Given this list of marker genes HLA-DRB1, DNA2 (NCBI Gene Id 1763), CYP27A1, MEIS2, NRCAM, VPS33B, UBAP2L, PIGB, KDSR, MAB21L2, GTPBP2, TBX22, FBXO11, BRCA1, USF3, POLR3GL, LUZP1, MPV17, OPA3, RNF2, TMEM216, STX5, YY1, XYLT1, CD96 (NCBI Gene Id 337949), CREBBP, USP9X, GATA6, SIN3A, TUFT1, BMP2, DGCR2, SOD1, SLC25A4, PRG4, SF3B4, DMD, TMEM260 (NCBI Gene Id 54916), SMO, RALA, BAG3, HNRNPH1, RAI1, KBTBD13, WASHC5, CCDC22, FLI1, AGA, ASXL1, CERT1, ERCC6, CUL4B, VCP, ZNF668, KIF7, SLC5A7, BUD23, CPT1C, PCGF2, WNK3, MYOD1, NFU1, SLC26A2, PARN, GRIN2B, LAMA3, HK1 (NCBI Gene Id 59333), BMPER, NPHP1, RAD51C, POLRMT, AHDC1, SUFU, IBA57, KIF1A, PCNA, TDP1, TTC21B, AMMECR1, PALB2, TRIO, MBTPS2, PDGFRB, COA7, LITAF, MYRF, BMPR1B, IFIH1, VPS13A, DLG4, ACBD6, GJB4, ADAMTS15, TPR, ATP1A3, MEF2C, SLC18A2, DNM2, RAB7A, SPEG, CASK, TRIM8, NLRP3, MYOT, KCNA1, TACR3, LZTR1, BRIP1, ABL1, HSPD1, BBS12, FGF14, TOGARAM1, DYNC2I1, ANAPC1, ITCH, RBM8A, RAD21, HEATR3, RINT1, TSPOAP1, B3GLCT, PTEN, ATG7, KRT74, HOXA13, POLR1A, CNTNAP2, ATP6V1E1, LMX1B, FLVCR2, ADA, PSAT1, GAN, MED25, IGF1R, GRHL2, SACS, PTH1R, ARMC9, ALOXE3, COL3A1, FGF8, TNNT1, ORAI1, BPNT2, MME, LTBP4, SCN4A, SLC9A6, ATPAF2, NPM1, KATNB1, BLTP1, DSG1, PRMT7, FGF9 (fibroblast growth factor 9), SPAST, SLCO2A1, BRD4, PQBP1, MCOLN1, SERPINA12, TCF20 (NCBI Gene Id 6942), FOXE3, CCN6, EXOC6B, YME1L1, DHTKD1, CSGALNACT1, MKKS, FLNA, SLC9A7, SPTLC1, RUSC2, GNPTAB, ALG2, NDRG1, GRIA3, RYR1, TUBB3, COL1A2, TRMT10A, IDS, ARL13B (ADP ribosylation factor like GTPase 13B), CRKL, SLC35A3, MATN3, CASZ1, CBY1, H1-4, IARS2, INPPL1, HCN1, REPS1, COL17A1 (collagen type XVII alpha 1 chain), KPNA3 (NCBI Gene Id 3839), KRAS, KLC2, SIL1, CTBP1, ALAD, BBS2, SETD2, PLAA, APC, DHCR24, SEC23A, PLA2G6, NAA20, GRIN2A, CACNA1C, MTRFR, CAVIN1, HEY2, KRT1, DACT1, RYR3, ALPL, HBA2, GLI1, PIGP, GNB4, GBE1, PEX2 (peroxisomal biogenesis factor 2), KDM5A, ASXL3, DCC, TAFAZZIN, SCN2A, CEP104, ARHGAP31, SGCG (sarcoglycan gamma), TFE3, POMGNT1, SMARCAD1, SYNE2, GORAB, NOTCH1, IQCE, FUZ, PDZD8, SPRTN, SVIL, LAMC2, DHX30, TAF6, MYO9A, NDE1, PRKACA, MAP1B, VLDLR, SLC17A5, CLCN3, NBN, DYM (dymeclin), MAP3K20, SLC33A1, ABHD12, CLCF1, SLC2A10, SIM1, FBXO38, BBS4, SNCA, IFT74, HSPB1, NOD2, PLEKHG5, GJA1, GLB1, REEP1, CDSN, WARS1, CTU2, DRG1, MUSK, TMEM138, TMEM107, MEG3, SLC39A13, STX1B, TNFRSF1B, KANSL1, MKRN3, CRIPT (CXXC repeat containing interactor of PDZ3 domain), CLTCL1, DLAT, POMT1, UBE3B, UBAP1, PIGL, TTPA, POR, NCF1, GJB2, FKTN, MMP14, USP7, ADAT3, AKT1 (NCBI Gene Id 207, AKT serine/threonine kinase 1), RMRP (RNA component of mitochondrial RNA processing endoribonuclease), NRAS, HGD, RFX7, RAB23, BCR, DLL4, WDR11, HACE1, ARL6IP1, BMP4, KDELR2, ERCC1, CAPN3, MYH14, RECQL4, GMNN, KATNIP (NCBI Gene Id 23247), FAM20C, CUL7, DNM1L, KIAA0586, CYP4F22, COL6A3, GTF2IRD2, FBN1, FGFRL1, PPIB, MED12L, KIF5C, NADSYN1, TMEM231, DMPK, PPP2R3C, SPG7, SATB2, BRPF1, ADGRG6, SYT1 (synaptotagmin 1), TGFB2, FBXW11 (F-box and WD repeat domain containing 11), TGFBR2, NECTIN4, ANO5, ANO10, SOX18, TOR1AIP1, LIMS2, PUF60, SMARCA2, PTCH2, TXNDC15, ZEB2, TELO2, MED13L, IFT43, GBF1, MEN1, TLK2, COL6A2, ASAH1, DNAJB2, ECEL1, GJA5, B3GALT6, RAD51, TRAPPC11, IFT52 (intraflagellar transport 52), MAFB, NPR2, CST6 (NCBI Gene Id 1474), UBA1, GMPPB, FREM2, PRKACB (protein kinase cAMP-activated catalytic subunit beta), TTI1, MYT1L, PLIN4, ACVR1, CC2D2A, NHP2, NPR3, ATCAY, MYL2, USB1, FANCG, ANK1 (NCBI Gene Id 286), BMS1, FDX2 (ferredoxin 2), FREM1, TBC1D23, COL2A1, TERT, PDE6D, MBD5, PRUNE1, ANO1, BBIP1, RBPJ, STAG1, FLRT3, CSNK2A1, MAP2K2, LMBR1, CBFB, EIF2AK2, RSPRY1, ORC6, DDHD2, DLK1, ZNF148, GTF2E2, FGF13, TLL1, KDM4B, INPP5E, LORICRIN, JUP, ANOS1, SNAP29, TAOK1, SUMF1, PDPN, SLC12A6, ZSWIM6, WIPI2 (WD repeat domain, phosphoinositide interacting 2), HERC2, RNF6, XRCC4, TCTN3, TBX15, EPS15L1, SORD, SALL1, C2CD3, CD4, CEP19 (NCBI Gene Id 84984), RHOA, ADGRV1, TAT, RAB11B, TPM2, GSC, FAM50A, PLOD3, SAMD9, U2AF2, WRN, HSD17B4, SOX10, MEGF8, VAC14, LARS1, ESAM, PIEZO2, CYP7B1, TBC1D24, PRKCG (protein kinase C gamma), TTC8, SCLT1, TRRAP, IFT122, RTTN, FGF17 (fibroblast growth factor 17), DNMT3A, EIF3F, SEC24C, PIGF, XRCC2, ADAMTSL2, AQP5, KIDINS220, HPGD, FGD4, TRAIP, MTOR, VPS13D, CAMTA1, MYPN, PTHLH, NUP188, SMAD4, USP8, KRT10, DOK7, KRT17, HDAC6, STS, IFT80, SCN9A, BIN1, NONO, MFN2, CEP290, MARS1, EHMT1, GMPPA, PACS1, COL1A1, MYMK, DHODH, UFC1, FKBP10, KIAA0319L, MAN2B1, FMR1, AP4B1 (NCBI Gene Id 10717), MAT2A, DCLRE1C, KLK11, IFT56, NEUROD2, DSC2, CACNA1A, LRP5, MFAP5, NT5C2, GDF5, NKX2-6, ZDHHC9, EBP, FDFT1 (NCBI Gene Id 2222), KANK2, H4C3, EXOSC3, DPH1, PAPPA2 (NCBI Gene Id 60676), MED12, CNTNAP1, SMARCAL1, PI4K2A, AEBP1, ZFYVE26, MAF, DYNC2I2, TBCK, DPH5, PRKAR1A, SMPD4, FGF10, KIF5A, MMP2, ABHD16A (NCBI Gene Id 7920), KCNK9, IGHMBP2 (immunoglobulin mu DNA binding protein 2), MAX, IDUA, HEPHL1, KLHL41, FXN, TRIM2, FHL1, COX7B, PDE4D, GJA8, SLC10A7, MAP2K1, EIF5A, KMT5B, KCTD1, SCN1B, SMG9, GFPT1, SLC25A22 (solute carrier family 25 member 22), MSTO1, TYMS, PHF6, SVBP, PYCR1, COL5A2, TRMT1 (tRNA methyltransferase 1), HIRA, EFEMP1, GABRD, NPAP1, MFSD2A, PDHA1, TH, JAG2, AFF3, MYH8, NUP88, LAS1L, DOCK6, CPT2, ACTB, SMARCA4, TRIP11, PTPN22, CHD6, BRWD3, RPGRIP1, MRE11, KCNJ5, RPL10, TRPV4, PEX7, TXNL4A, OTUD6B, MET, TBX5, RBBP8, STAC3, TTI2, PITX1, PYROXD1, AHCY, COQ8A, KRT83, ARL6, DHX16 (DEAH-box helicase 16), INSR, GNPTG, FBXL4, WAC, PTRH2, COL7A1, B4GALT7, FGFR3, ZBTB20, SEMA3A, SLC25A1 (NCBI Gene Id 6576), UPF3B, HNRNPK, NF1, METTL23, EIF4A3, ATAD1, ERBB2, KMT2D, FGF16, RLIM, SOX4, LETM1, EMG1, SYNJ1, WASF1, EIF2S3, PRRT2, IRF5 (NCBI Gene Id 84729), BBS9, NXN, ERLIN2, SMS, ELN, REV3L, THOC6, MTMR14, CCNQ, CEP120, NEK9, CDC45, ARID1A, TGDS, C19orf12, PHF8, LIG4, CEP152, BHLHA9, LTBP3, PI4KA, EOGT, PMM2, SOX9 (NCBI Gene Id 6662), HOXD13, WNT10B, RNU4-2, B4GAT1, MTM1, SLC35D1, XYLT2, TFAP2B (NCBI Gene Id 7021), PEX6, CNOT2, PLK4, VIPAS39, KNSTRN, BMPR1A, NDN, TRMT5, ERCC5, ABCA12, HADHA, SYNE1, TBR1, FKRP, GPC4, KIF22, ACTA1, TAF4, FRAS1, WDR19, ARCN1, CDK10, RTL1, VRK1 (NCBI Gene Id 7443), COMT, PEX1, HAAO, TCF4, KRT85, NLRP1 (NCBI Gene Id 82286), VPS35L, ACTA2, KAT6B, KDM5C, HPRT1, SLC6A9, AAAS, SLC25A19, DDR2, POMGNT2, CAPN1, ORC1, CLCN4, MLXIPL, FBLN1, JPH1, ATR, UBE2A, ADCY6, ADSS1, RSPO2, TMEM237, CFL2, GALC, CTH, RELN (NCBI Gene Id 5649), FANCM, NDST1, MGP, GHR, NIPBL, SELENON, NEK8, MAN1B1, GAD1, TAF8, MSX1, LEMD3, ALMS1, HBA1, MYH7, YARS1, ATRX, AP4M1, RREB1, TBL2, BSCL2 (NCBI Gene Id 84753), BBS5, TMEM67, PEX5, SNX14, SNRPN, PNPLA6, FA2H, COMP, COL13A1, ATRIP, ADPRS, DSP, KIF1B (NCBI Gene Id 57598), DGCR6, PPP1R15B, MAPK1, ZNF423 (NCBI Gene Id 23090), AUTS2, TBX1 (NCBI Gene Id 7413), CIC, TCTN2 (NCBI Gene Id 79867), HADHB (NCBI Gene Id 3032), SERPINB7, PHYH, APTX, HEXB, GOSR2, KIAA0753, KRT5, NUP107, SMARCD2, TAF1, NDNF, SASH1, FIBP, CHST11, RXYLT1 (ribitol xylosyltransferase 1), GFM2, HUWE1, RFWD3, ALDH18A1, ATP2B1, PNPT1, GDF6, GNAS, H4C5, FBN2, EIF4H, CERS3, FLNB, DPYS, PTPN2, CAMK2G (calcium/calmodulin dependent protein kinase II gamma), KIAA0825, PEPD, ERF, BGN, NUP85, NSD2, VWA1, CDC42BPB (CDC42 binding protein kinase beta), HIVEP2, RIN2, TBC1D2B, CARS1, SIK1, POMK, SMC5, HTT, APC2, TRPM4, NKX3-2, SEM1, EGR2, WRAP53, SPART, FOS, NECTIN1 (nectin cell adhesion molecule 1), PDK3, SLC37A4, CCDC8, BBS10, RAB34, WNT7A, CTSC (NCBI Gene Id 50958), SCNM1 (NCBI Gene Id 79005), ALG8, RBM10, LAMA5, WLS, TRPM3, SDCCAG8, LRSAM1, FBXO7, PUM1, GCH1, HNRNPA1, COQ7, HARS1, STXBP1, FANCD2, NIPA1, ARSL, RET, DLG5, BAZ1B, IFT57, PLXND1, IQSEC2, COL11A2, SLC25A46, KCNH1, CBS, ASCC3, ERCC4, DYNLT2B, FANCL (FA complementation group L), FANCI, SBF2, CHRM3, PRR12, SCARF2, ASPH, NELFA, SOX5, DDHD1, KCNJ2, SUZ12, VARS1, CCR6, SMC1A, FAT4, TWIST2, CENPE, IL7R (NCBI Gene Id 3575), THSD4, UBE2T, GJC2, DDX11, IRF6, MTR, GNAI1, PIGG, NTNG1, ERGIC1, MIR17HG, ZNF141, RFT1, GBA2, MAGEL2, CADM3, DNAJC30, CD247, PEX10, HNRNPH2, AMER1, CCDC28B, PLOD1, SLC25A24, DUSP6, PSMB8, SHH, WWOX, DPM1, SHMT2, ARVCF, SGCA, RNU4ATAC, RPS6KA3, TRIP4, GNAO1, SPG11 (SPG11 vesicle trafficking associated, spatacsin), CFAP418, DONSON, DYNC2H1, NKX2-5, TONSL, ALDH6A1, HS2ST1, OTUD5, NEFL, ZIC3, SPEN, LGI4, PIGA, GJB1, NAA10, CSPP1, CPLANE1, VPS41, ATP1A2, FOXG1, FAM149B1, MTX2, DNAJC6, MSL3, ADK, TRIM32, ZMYM2, PLAAT3, PTCH1, NSDHL, SMAD3, AP1G1, CHMP1A, ASNS, H3-3A, ROR2, SLX4, MYMX, KCNN3, GABRA1, SRD5A3, TERC, PPM1D, CCNK, KYNU, COL12A1, PLEC, ALG12, COL6A1, CAV1, CIBAR1, ERI1, WNT5A, ATP2A2, RAB3GAP1, SON, CPLX1 (complexin 1), RIT1, TCTN1, SCYL2, ARID1B, TMEM94, TBX4, AP1B1, CRLF1, PMPCA, SLC4A10, CLIP2, TET3, PRX, ATP6AP2, TGM1, NEDD4L, TOR1A, HEPACAM, KLLN, B4GALNT1, NSD1, JMJD1C, GALNT2, TBX3, PPP2R1A, ANKRD55, HS6ST1, FERMT1, IL2RB, DMXL2 (Dmx like 2), ERCC8, HINT1, KRT6B, EXT2, SPTBN1, CHD8 (chromodomain helicase DNA binding protein 8), PPARG, PIK3CA, EIF2AK3, FKBP6, IL17RD, PCDHGC4, DSE, LRP4, SYT2, DGCR8, CTSK, SLC29A3, GNS, OBSL1, ERMARD, XPA, WDR35, TWNK, PRDM16, METTL27, SCN1A, RSPO1, BAP1, SNORD115-1, FANCE, ADAMTSL1, GPC3, TGFB3, DDX59, KAT6A, COG6, NSUN2, CAV3, COL4A1, CCDC47, SPTAN1, CHRNG, CAST, UBA2, TMTC3, ERCC2, LONP1, COL25A1, GRIN1, OPA1, BBS7, VPS37D, SPRY4, B3GAT3, AIFM1, PNPLA1, MECP2, WARS2, CHSY1, HNRNPA2B1, GNB1, ARL6IP6, LBR, UFD1, DPAGT1 (NCBI Gene Id 1799), ITPR3, POGZ, DLX5, CANT1, RETREG1, CHST3, NDUFAF6, PIBF1, PROK2, DCPS, CTSB, SMAD2, DYRK1A, B3GALNT2, DPM3, SMARCE1, SDR9C7, GRIP1, BICD2, ATP9A, TMEM270, MAN2C1, CILK1, DDX6, FARS2, AHI1, NFIX, SMC3, GATA4 (GATA binding protein 4), PDXK, TMCO1, HERC1, SEC23B, INTS8, SCAPER, EDEM3, TNNI2, FLII, SIGMAR1, PIK3CD, LMNA, FBXW4, NEFH, PRKCZ, B9D2, ATL3, DAG1, PCDH19, DLEC1, INTS1, IVNS1ABP, TDO2, IFRD1, ZMIZ1, SBF1, CCN2, GLI3, ARSI, PEX26, EXT1, MYCN, FLRT1, TRPV3, FANCA, ATP7A, LMBRD1, TRIP12, ATP13A2, COL27A1, TINF2, ZMPSTE24, MYH11, TMEM218, SETX, LMNB2, PIGS, MAPRE2, CHST14, ESS2, SCAF4, SRY, MRAS, WDR26, MTMR2, C1R, NKAP, NPHP3, SHROOM4, BTRC, MMP1, EVC2, AIP, ROBO1, LIFR, NOTCH2, GNA11, TBL1XR1, TMEM43, HDAC8, SULT2B1, MTTP, GDF11, ADAMTS10, DCHS1, MYL11, EFNB1, PRKD1, PHGDH, PMP22 (NCBI Gene Id 5376), LIPE, RPGRIP1L, BCOR, BBS1, CTCF, MCTP2, MAP3K7, DVL1, PPP3CA, BRCA2, PWAR1, KMT2A, CHD3, EN1 (engrailed homeobox 1), VPS13B, EED, FANCF, NARS1, IFT27, RERE, COPB1, MAD1L1, FGD1, EZH2, FANCC, SEC31A, ATP6V0A2, EEF1A2, GZF1, SCYL1, KMT2B, IRX5, IL6ST, NBAS, ZNF699, MGAT2, WNK1, IMPDH2, HACD1, POLR3A, CKAP2L (NCBI Gene Id 150468), CDH3, WBP4, POMT2, HNRNPR (NCBI Gene Id 10236), GABRA3, PRKG1, COL11A1, STX1A (NCBI Gene Id 6804), NEB, ATP6V1B2, WDR73, ZC4H2, SLC35C1, OFD1, UBE4B (ubiquitination factor E4B), PLP1, COG8, PIGQ (NCBI Gene Id 9091), KRT9, ATP6V1A, CHCHD10, PAICS, MMP23B, COG4, VAMP1, MEGF10, SNIP1, GJB6, PRDM5, CRPPA (CDP-L-ribitol pyrophosphorylase A), SLC32A1, SLC39A8, COASY, SDHC, REEP2, TAF2, NR4A2, CDC42, BCAS3, PMP2, COX4I1, GRIA2, CEP295, PODXL, ATL1, KCNJ8, ADAMTS2, AAGAB, SH3TC2, STAG2, SEMA3E, SLC31A1, FGFR1 (NCBI Gene Id 84151), PLOD2, SCO2, IFT172, FEZF1, WDPCP, RAG2, GRIN2D, IFT140, ADNP, VANGL1, HOXD10, TPM3, DYNC1H1, H4C11, NOP10, NIPAL4, SIK3 (SIK family kinase 3), PPP1R21 (protein phosphatase 1 regulatory subunit 21), SLC16A2, RHBDF2, L1CAM, CEP55, NEK1, PROKR2, HRAS, KY, EMILIN1, SLURP1, CSTA, FANCB, KRT2, PIGH, PYCR2, LIMK1, GABBR2, SKI, COL14A1, SLC1A3, AP4S1, GRM7 (NCBI Gene Id 2917), KRT6A, RIPK4, SNORD116-1, KCNAB2, SETD5, IPO8, EXTL3, IL2RG, KARS1, H3-3B, ATP5F1D, HSPG2, GNPNAT1, SAMD9L, COL9A1, MAD2L2, EPB41L1, LAMB2, NGLY1, CCT5, UCHL1 (ubiquitin C-terminal hydrolase L1), POLG, ZNF469, GATAD2B, MT-TE, FGFR2, TYROBP, C18orf32, ALOX12B, BRAF, ALG3, DKC1, KRT14, SC5D, CTDP1, ZFX, PNKP, DYNC2LI1, SH3PXD2B, CEP41, TRPS1, LARGE1, CNOT3 (NCBI Gene Id 9756), EMD, TFG, ITGB4, SALL4, SLC1A4, RAB33B, MORC2, TGFBR1, COL5A1, LAMB3, BRF1, RAB3GAP2, PHIP, RAP1GDS1, FIG4, PIGV, COL9A3, GUSB, RTEL1, GABRG2, POMP, PKP1, GPX4, SDHD (succinate dehydrogenase complex subunit D), FRA10AC1, RAG1, DHH, PWRN1, WDR81, CHAT, CRELD1, PPP1R13L, ENTPD1, GBA1, MAPK8IP3, INF2, GTF2IRD1, ENPP1, NOG, CCDC141, SLC35A2, HSPB8, IL2RA, TP63, SPECC1L, TTN, JAG1, SIAH1 (NCBI Gene Id 6477), MPZ, AGPAT2, SHANK3, SARS1, EBF3, KLHL24, PCNT, H4C9, LAMP2, CD28, SPIN4, RFC2, ARX, HYLS1, GARS1, GDAP1, CTLA4, MRPS28, UNC80, ALDH1A2, TOPORS, VAPB, ALG9, IHH, PIGN, WNT10A, ATN1, SHOX, MYLK (myosin light chain kinase), GLDN, COLQ, AP4E1, CDKL5, IFITM5, TGFB1, KLHL9 (kelch like family member 9), DHCR7, MYBPC1, FILIP1, GP1BB, POC1A, SLC6A8, PRKG2, TWIST1, STAT4 (NCBI Gene Id 6775), CTNNA2, CHP1, MYH3, SLC12A2, TNNT3, GTF2I, NALCN, PPP2R5D (protein phosphatase 2 regulatory subunit B'delta), CFTR, DCAF8, TBCE, KAT8, DEAF1, ALG14, GNE, GLE1 (NCBI Gene Id 8012), FKBP14, GJB3, PIGO, FITM2, BPTF (bromodomain PHD finger transcription factor), DES, CCBE1, LOX, CACNA1B, SPTBN4, LZTFL1, PRPS1, MKS1, SATB1, SLC39A14 (solute carrier family 39 member 14), ABCC9, KIF14, MIA3, PIGY (NCBI Gene Id 84992), KRT6C, KL (NCBI Gene Id 9365), CHN1, EXOC7, ADAMTS3, TRAF7, SPRED2, ATAD3A, DST, CHD7, ALS2, OCA2, FBLN5, MASP1, RTN2, DYSF, GPR101 (NCBI Gene Id 83550), ARL3, AGRN, SETBP1, MCM3AP, ATP1A1, RNU12, CLDN11, COX6A1, ACAN, SNAP25, EVC, CTC1, EP300, SLC18A3, ODC1, TCF12, IL11RA, PORCN, POU3F4, LSS, SDHB, ITPR1, DLX6, ITGA8, ESCO2, PHEX, HDAC4, PERP, NFATC2, GNB2, HESX1, JARID2, SMOC1, AARS1, KRT16, CARD14, B9D1, C12orf57, DPH2, CWC27, ZNF407, ITGA7, COG1, here is a description of the gene set: Human Gene Set: HP_ABNORMAL_FOOT_MORPHOLOGY An abnormality of the skeleton of foot. studied in species Homo sapiens Abnormal foot morphology